Given this list of marker genes Lamp1, Rack1, Khk, Pter, Idh1, Cotl1, Krtcap2, Cd63, Rps10, Lap3, Aldob, Rps2 (NCBI Gene Id 16898), Snx7, Rpl38, Ddah1, Rpl36a, Nme2 (NCBI Gene Id 18103), Ak2 (NCBI Gene Id 52171), Xist, Mif, Mgst1, Bola2, Apoe, Psmg4, Uap1l1, Ttc36, Psap, Sh3bgrl3, Acox1, Tkfc, Ftl1, Tmem256, Slc5a2, Itgav, Rps19, Timm13, Bax, Tmem205, Neu1, C130074G19Rik, Rpl12, Spmip3, Lamp2, Gpx1, Prxl2a, 4931406C07Rik, Grina, Acsm2, Mep1a, Fbp1, Tmem174, Vcam1, Ldhb, Glyat, Eif6, Comt, Tmbim4, Rpl27, Aldh2, Tmem254, Calml4, Ctsz, Hsd3b4, B2m, Arl6ip1, Cndp2, Cxcl16, Dhrs4, 2200002D01Rik, Rpsa, Cyba, Spp1, Napsa, Cltrn (collectrin, amino acid transport regulator), Sult1d1, Gng12, Rpl39, Picalm, Rps13, Cib1, Lrp2, Mgat4b, Gss, Nus1, Lgmn, H2-D1, Tmem176b, Slc4a4, Scp2, Fut9, Rpl41, Ccng1, Dhcr24, Msra, Cat, Fth1, Hint1, Sfxn1, Dab2, Ets2, Ufm1, Tmem258, Steap2, Cyp2j5, H2aj, Gstm5, Akr7a5, Tnfrsf12a, Esd, H2-Aa, Gipc2, Rpl23, Gc, Ggt1, Pebp1, Rps28, Kap, Gpx3 (NCBI Gene Id 14778), Pdzk1, Ddit4l, Nme1, Tagln2, Rplp0, Ndrg1, Ly6e, Cp, Defb29, Iah1, Hspe1, Akr1a1, Dnajc19, Rps15a, Ivns1abp, C3, Rpl32, Acot13, Spink1, Rps12, Npc2, Itgb6, Ccnd1 (NCBI Gene Id 12443), Fermt1, Nhp2, Gcnt1, Rps27l, Gatm, Cstb, Lgals3bp, Guca2b, H2-Eb1, 1110038B12Rik, Pah, Selenop, Rbis, Cldn10, Bst2, Hao2, St13, Rplp1, Rps21, Mdk, Rps16 (NCBI Gene Id 30901), Miox, Sytl2, Ctsb, Cd74, Uqcr10, Keg1, Tpt1, Eny2, Phlda3 (pleckstrin homology like domain, family A, member 3), Tmem176a, Slc25a39, Rps17, Gas5, Igfbp4, Slc27a2, H2-Ab1, Gsta2 (NCBI Gene Id 14858), Ly6a, Rps18, Lgals1, Slc34a1, Rida, Pdzk1ip1, Eef1b2, Tmem252, S100a10, Atox1 (antioxidant 1 copper chaperone), Myof, Rplp2, H2-K1 (NCBI Gene Id 56628), Cryz, Dbi, Akr1c21, Rpl37, here is a description of the gene set: Mouse Gene Set: TABULA_MURIS_SENIS_KIDNEY_PODOCYTE_AGEING species: Mus musculus from publication Tabula Muris Consortium (PMID 32669714)